The following is a description of a gene set: Human Gene Set: HP_ABNORMAL_MUSCLE_FIBER_ALPHA_DYSTROGLYCAN studied in species Homo sapiens A deviation from normal of muscle alpha-dystroglcan expression. Alpha-dystroglycan is a heavily glycosylated peripheral-membrane component of the dystrophin-associated glycoprotein complex (DAPC), which, in addition to laminin alpha2, binds perlecan and agrin in the extracellular matrix, whereas beta-dystroglycan, derived from the same gene, is a transmembrane protein that links to dystrophin intracellularly. Abnormal muscle fiber alpha dystroglycan, and this is the list of marker genes: DAG1, GMPPB, POMGNT1, FKTN, POMK, POMT2, POMT1, CRPPA, GOSR2, FKRP, HMGCR, LARGE1